Given this list of marker genes ZNF16, LGALS3, TBC1D12, DNAJA2, MMP1, DIAPH1-AS1, COL1A1, TMPRSS11E, GAS2L2 (growth arrest specific 2 like 2), INPP5D, SMIM31, CYTOR, HELLS, AFG3L1P, SEC11C, UBE2S (NCBI Gene Id 27338), STARD7, DHRS7B, SLC52A2 (NCBI Gene Id 79581), RASD1, TRIM62, SRA1, STOM, ETNK2, TKTL1, RTL6, GPATCH1, NAA80, TRIML2, C1orf53, CAMK2N1, TBK1, EPHA4, HLA-DPA1, PRDX1, GPR137B, ICA1, NUP62, SCO2, SDF2, KLHDC10, SND1-IT1, ELL2, C12orf75, CTSH, FXYD7, P2RY14, FBXO45, RGN, TUBB3, PSMB2, ITIH1, P4HB, TMX4, CCNF, NOD2, E2F8, ANO6, MTHFD2, SMIM13, PARD6A, CMTM3, ACTR1A, NOL10, ITPK1, VWA5B1, PGM1, MBOAT1, SOWAHC (sosondowah ankyrin repeat domain family member C), CFH, WNT10A, SRP72, TYW5, ASL, CD109, COPS3, AMDHD2, FRMD4B, SPTBN4, CHSY1, HES6, STX1A, BSG, FREM2, TMEM38A, PRXL2C, MGST2, NAB1 (NCBI Gene Id 4664), TMEM59, MIB1, UBE2T, SPON1, ELK3, RMC1, NECTIN3, SIAH2, CYB5D1, GNG2, SPRED2, TUBGCP4, IGFBP3, PRNP, FAM110B, MPST, BTRC, LGALS1, COX5A, POLE2, GALT, DONSON, KIT, SMCO4, CHMP1A, CXCL16, PTTG1, CSPG5 (chondroitin sulfate proteoglycan 5, NCBI Gene Id 10675), LINC00305, SCYL3, ATG5, SPATS2 (spermatogenesis associated serine rich 2), PTPN13, ALOX5 (arachidonate 5-lipoxygenase), PHLPP2, ODF2L, MUSTN1, RHOC (NCBI Gene Id 389), SLC2A3, CD58, MRC2, RBBP7, CACNG2, ATP6V1F, KLHL4, MMP17, RUNX3, POLR2F, EPS8, STIMATE, PIKFYVE, SH3BP1, CYB5R4, ST8SIA1, MARCKS, SETD3, LIMS1, ZNF142, DNAJC15, F12, HIVEP3, VN1R3, PITPNA, ZFYVE28, PTTG3P, PHTF1, CLEC4G, IGHV7-81, NPDC1, MIR21, UBE2L3, ACAN, TMED1, FBXO28, CEP164, TAF3, KRTAP4-1, TP53BP1, ST6GALNAC1, BLOC1S2 (NCBI Gene Id 282991), UST, HMCN2, CREB3, POMT1, VRK2, TSPAN15, IL2RB, KEAP1, NEU1, TXNDC11, PLEKHG1, GALM (galactose mutarotase), LATS2, GNS, SCAF11, SYT11, RILPL2, CIPC, NSD2, LMNA, SEC14L1 (SEC14 like lipid binding 1), TBX15, VSTM2A-OT1, GPR65, FERMT3, here is a description of the gene set: from publication Chevalier N, Jarrossay D, Ho E, Avery DT, Ma CS, Yu D, Sallusto F, Tangye SG, Mackay CR (PMID 21471443) Genes down-regulated in comparison of naive CD4 T cells versus CD4 central memory T cells. Human Gene Set: GSE26928_NAIVE_VS_CENT_MEMORY_CD4_TCELL_DN species: Homo sapiens